The following is a description of a gene set: from publication Onken MD, Ehlers JP, Worley LA, Makita J, Yokota Y, Harbour JW (PMID 16651410) Genes up-regulated in uveal melanoma: class 2 vs class 1 tumors. species: Homo sapiens Human Gene Set: ONKEN_UVEAL_MELANOMA_UP Microarray gene expression profiling is a powerful tool for generating molecular cancer classifications. However, elucidating biological insights from these large data sets has been challenging. Previously, we identified a gene expression-based classification of primary uveal melanomas that accurately predicts metastatic death. Class 1 tumors have a low risk and class 2 tumors a high risk for metastatic death. Here, we used genes that discriminate these tumor classes to identify biological correlates of the aggressive class 2 signature. A search for Gene Ontology categories enriched in our class-discriminating gene list revealed a global down-regulation of neural crest and melanocyte-specific genes and an up-regulation of epithelial genes in class 2 tumors. Correspondingly, class 2 tumors exhibited epithelial features, such as polygonal cell morphology, up-regulation of the epithelial adhesion molecule E-cadherin, colocalization of E-cadherin and beta-catenin to the plasma membrane, and formation of cell-cell adhesions and acinar structures. One of our top class-discriminating genes was the helix-loop-helix inhibitor ID2, which was strongly down-regulated in class 2 tumors. The class 2 phenotype could be recapitulated by eliminating Id2 in cultured class 1 human uveal melanoma cells and in a mouse ocular melanoma model. Id2 seemed to suppress the epithelial-like class 2 phenotype by inhibiting an activator of the E-cadherin promoter. Consequently, Id2 loss triggered up-regulation of E-cadherin, which in turn promoted anchorage-independent cell growth, a likely antecedent to metastasis. These findings reveal new roles for Id2 and E-cadherin in uveal melanoma progression, and they identify potential targets for therapeutic intervention., and this is the list of marker genes: IFITM3, PTRH2, NR4A2, CBFB, GDF15, RCBTB1, CYC1, TYMP, GALNT7, SOS1, PTGS1, FKBP1A, NUDT15, LRP1, SSX1 (NCBI Gene Id 6756), SORD, FNBP4, CTSB, NETO2, TTC3, CDKN1A, USP48, PKD2, ANP32E, IMPA1, MTSS1, PPIP5K2, ZC3H7A, ATP6V1H, LTBR, ATG14, PFN1, TRAF5, NOTCH2NLA, PSME4, MTERF3, TRA2A, CDC42EP3, UBE2V2, THUMPD2, LSM14A, FLNC, UBR5, MPC1, APPBP2, PCMT1, ATM, SLC2A3, STK3, BAZ2B, LGALS3, BICD2, ZNF706, EXOSC8, GPR107, PHF20L1 (PHD finger protein 20 like 1), BTN3A3, TERF1, UFL1, DPY19L4, GSPT1, COX6C, PLEKHF2, MMP2, KPNA2, ZNF623 (zinc finger protein 623), FASN, HERC2, SHTN1, MEX3C, ADGRL1, DENND5A, SPAST, INPP4B, RPL37A, ASS1, TAGLN2 (NCBI Gene Id 8407), SRSF7, NASP, CDC25B (NCBI Gene Id 994), CDC42BPB, PNISR, PSAP, ABTB2, ASB9, PSMB9, SLC23A2, AHI1, HNRNPD, ANK2, PSME2, SLC25A13, PDLIM1, GPAA1, GEMIN6, RPS6KA2 (NCBI Gene Id 6196), CALM1, RAI14, ARRB1, AUH, DLST, CTPS1, MSN, PRKCA, ARMC9, MTDH, FADS3, YTHDF3, STS, PILRB, CUX1, LY96, PITPNC1, H2AX, PRDX4, AHNAK2, POLR2K, HK2, KCND3, CASP1, PARP12, SPTBN1, COPS8, HLA-DMA, RABGAP1L (RAB GTPase activating protein 1 like), POLR3C, PCGF2, SOCS2, GTF3A, ASAP2, HDAC4, FNBP1, C1QB, MED15, WWP1, CTSH, TAF2, ACIN1, GGNBP2, FEZ1, TMEM70, CALR, BAIAP2, POLA1, SRSF11, SCD, CDH1, ELOVL6 (NCBI Gene Id 79071), RDX, P4HA1, TBC1D16, DNAJC10 (DnaJ heat shock protein family (Hsp40) member C10), TYMS, GATAD1, PIK3C2A, PDE4A (phosphodiesterase 4A), EFHC1, DAPK1, GOLM1, RECQL, NRDC, TOR1AIP1, PEA15, PTDSS1, ZMYND8, SLC45A2, MFSD10, ARFGEF2, SNRPA1, ME2, IFITM2, STOM, PTPRM (NCBI Gene Id 5797), CHD3, RAP1GDS1, HSD17B12, TPR, BOP1, HACD1, AZIN1, COL18A1, C8orf44, COL4A1, NSMF, TNPO1, PTPA, OPN3, PCNA, IARS1, MAP3K12, ELOC, SORL1, ABCC1, HTATIP2, VOPP1, GUSB (glucuronidase beta), KPNB1, WSB1, MPHOSPH9, G6PC3, JAG2, EIF4G3, LAPTM5 (NCBI Gene Id 7805), MGAT2, SPATA20, CCND2, PTGER4, GSDMD, GLRX2, UGGT2, MET, SEC63, NDUFA6, TGS1, MINK1, SH3YL1, PTPRC, SNW1, SPARC, NFATC2IP, MICAL1, CAVIN3, GNS, ZC3H11A, UBXN2B, ADGRA3, DAP, PPP1R12A, FZD7, HLA-B, GDI1, ASAP1, CTSS, PFKP, RALGAPA1, DMXL1, CDK1, HLA-E, OXCT1, RUFY3, TSPYL5, SCO2, SACS, ADAM23, DLG5, GREB1, TNKS2, NIPA2, FGF13, ANXA4, TM9SF2 (transmembrane 9 superfamily member 2), HCLS1, CDC42BPA, CBR1, BIN1, SHC1 (NCBI Gene Id 6464), LZTS1, PHF11, RBFOX2, NACC2, RRN3, CCNDBP1, BTAF1, BMERB1, BAG2, SOD2, SNRNP35, PHF21A, MYO18A, OTUB1 (NCBI Gene Id 55611), C2, ATMIN, CDK5R1, HMGXB3, MXRA7, PLAAT4, TENT4A, PSMA7, TSPAN31, RBM28, LETM1, OLFM1, SNRPG, GNPTAB, ENY2, RAP1GAP, PSRC1, NFIL3, ATP2A2, ZNF84, CHD7, LYN, FABP3, ABR, CYP51A1, DLGAP5, SERINC5, TMEM164, ACADVL, RPL17, LAMC1, NDRG1, PRKDC, ACSL1, RNF139, FHL1 (NCBI Gene Id 2273), IGFBP7, WBP1L, DDX60, SULT1A2 (NCBI Gene Id 6799), FZD5, ADI1, WLS (Wnt ligand secretion mediator), ZBTB10, PSMB1 (proteasome 20S subunit beta 1), CHST3, MARCHF7, SNX16, PDS5A, YWHAZ, TCF12, RBMS1, SYNCRIP, ANXA11, CYRIB, INTS8, TM2D1, AK4, PKM, MEIS2, MAP4K3, CKS2, RAB31, EXT1, ADGRG1, DNAJC13, OXR1, CDK17, NSMAF, ALK, VLDLR, CPNE3, RAD21, HAUS3, SPTAN1 (spectrin alpha, non-erythrocytic 1), KIF14, C1R, EGR3, TPD52, ACLY, PSMA3, KIAA0232, MACF1, SHFL, AP1G2, RPGR, APP, SLC1A4, WARS1, RMDN1, ACACB, TMEM87A, IFITM1, WWTR1, MAD1L1, LARP1, HSPH1, ORMDL2, IER5, DDX39A, TMCO1, UBXN4, PAM, ATP2B1, NCOA2, TSC22D1, NPAS2 (NCBI Gene Id 84195), NF1, ASTN2, CHCHD7, VSIG10, FXYD6, PTPN2, HMGB2, RDH11, PTK2, RIN3, LAPTM4B, MSL1 (MSL complex subunit 1), CNIH4, MRPL19, EBAG9, GSS, CAMSAP2, CPSF1, PLTP, ZNF267, CEBPD, SLC22A18, CDC27, NDUFB8, REV3L, MLH3, NTAN1, LHFPL2, CDC16, GPR143, RCAN1, RHOT1, RAB2A, MRPL15, EMP1 (epithelial membrane protein 1), CIAO1, C1QA, VCPKMT, SLC25A32, NUCB2, MRPS28, ISG15, MORC2, MRM2, WASHC5, NPIPB3, C8orf33, PCDH7, FASTKD1, CLIP1, PLOD3, SMARCA5, MAP2K3, DERL1 (derlin 1), TMEM168, ENOSF1 (NCBI Gene Id 55556), IQGAP1, ZNF451, SUPT16H, NQO1, CCNA2, TCEA1 (NCBI Gene Id 7865), UBE3A, ZFP36L2, WIPI1, MED7, DIAPH2, NUMB, HCFC1R1, TRIO, GPR89B, B2M, AUP1, LHFPL6, MT2A, NUSAP1, ATP6V1C1, ARFGEF1, IDE, SPARCL1, REEP1, PFKFB3, EIF4EBP3, SAFB2, TPP2, RHOB, HERC2P9, PIN4, ADGRE5 (NCBI Gene Id 976), S100A13, PXDN (peroxidasin), PEX2, CXCR4, SLC20A1, CSPG4, CERS2, NANS, FBXL7, COQ2, COTL1, ANKRD46, LYPLA1, SMARCA4, VPS13B, CDK19, PUM3, SLC38A6, CAPN2, HNRNPDL, ADCY3, LRRFIP1, CD58, COL1A2, WWC3, P4HA2, BCOR, IER3, RAD54B, SGK1, IFI16, HLA-G, DOCK9, KNOP1, HTRA1, BDH2, DOCK4, SLC7A8, TRIM22, ADCY1, NT5E, LAMA5, ITGA6, NT5DC3, COPS5, ZDHHC11, POMP, C2CD2, TRBC1, MAN1C1, CTSK, TTC28, ETS2, DUSP14, TMEM165, KDR, DCAF8, TPBG, FAM174B, ANKRD10, FADS1, VMP1, FRY, AP1S1, UBE2S, APOD, EMC2, TIMP2, PFN2, PTP4A3, UBE2K, LGALS8, CERS6, FAM193A, FAM216A, EML3, BAZ1A, ADAMDEC1, PCGF3, TNFAIP2, SGSH, IRAK1, GNAS, SYNE2, JMJD1C, SEC24D, GBA1, BASP1, CD55, ADAM17, CNOT4, RNF144A, COL6A1, PGAM1, CLIC4, EGR1, ACTB, HDAC1, CENPU, TBC1D1, DECR1, TYROBP, SLC35E3, FGF9 (fibroblast growth factor 9), ATP10A, IGF2R, NUP88, MRPL40, NCOR1, NME4, CD74, RGS20, VPS28, SMAD3, KDELR3, PDE10A, SETDB1, RBM25, MACROD1, IFNGR1, LAMTOR2, ACKR3, PTPRA, TRAM1, LINC00342, LDB3, OGT, MR1, ABHD3, QDPR, EFR3A, PRUNE1, TBL2, NAT10, SOX13, RETREG1, HNRNPA1, TMEM38B, ITPR2, LDLRAD4, S100A1, TRPV2, HLA-DRA, FCER1G, CLEC2B, HLA-J, PSPC1, CCDC93 (coiled-coil domain containing 93), CELSR1, SCAMP4, TPST2 (tyrosylprotein sulfotransferase 2), MGST2, PIGA, ACTR3, PLXNC1, HLA-DRB1, STAM, S100A6, MARK3, GCH1, IDH2, SEPTIN10, LAP3, C4A, MYO6, PIK3C3, PRP4K, RB1CC1, SEPTIN2, SQLE, TFPI2, SDHA, FXYD5, NBN, ALG5, MCM4, EMC7, RIDA, CTSC, SOAT1, CREM, FABP5, LY6E, ADCY9 (adenylate cyclase 9), CTTN, DGAT1, TRRAP, PLPP3, NPIPB15, LGALS1, ME1, TRIB1, COMT, PGAP1, CAPRIN2, FAR2, BAZ1B, ASF1A, NPIPA1, URB1, TIA1, CDK2AP1, SGCB, TMEM214, FKBP11, PTOV1, LRP8, NUP58, SFPQ, DNAJC2, NOX5, TRIM33, IPO9, SEL1L3, MEMO1, ARMC1, PMM2, ZNF410 (NCBI Gene Id 57862), IFFO1, UBE2W, TCERG1, GFUS, GOLPH3, S100A11, GRINA, PRRC2C, RGS5, MAN2A2, TDG, MTR, SP110, CLINT1, MCM3AP, AACS, SMCHD1, KCTD12, SLC11A2 (solute carrier family 11 member 2), STAT1, CITED1, PCDHGC3, MYOF, AKAP9, EMP3, CASP8AP2, ATP9A, LUC7L3, TAPBP, SLC1A1 (NCBI Gene Id 6505), ALG13, CELF2, HLA-DPB1 (major histocompatibility complex, class II, DP beta 1), ZNF7, SREK1, ARPC2, NXN, ZEB2, SAMD4A, SLC35A1, EXOSC4, AKAP13, TACC2, ZHX3, HSPB8, LUC7L2, TRAPPC10, TRAF3, PDXK (pyridoxal kinase), ARHGAP1, SULT1A1, SH3BGRL3, AGO2, CCN3, KDM7A, PUS7, SFI1, PHACTR1, PPP1R10, STAT6, TBK1, HLA-DPA1, PDE4DIP, EIF4E2, SFXN3 (NCBI Gene Id 94083), BOLA2, CADM1, TNFAIP8, MTCL1, TRAPPC13, IRF9, NENF, KIT, SPIDR, SULT1A3, MBD2 (NCBI Gene Id 8932), ACTN4, NEK3, MTFR1, SAP30, SYNPO, MRPL13, FRMD4B, HLA-F, GEM, BIRC7, PHLDA2, SLC39A4, RAPGEF4, SPON2, SAR1B, MTX1, LACTB2, UQCRB, ASPH, PSMD14, WIPF1, ODR4, CSPP1, AGAP1, DGCR2, AMZ2, APOBEC3G, GLA, NOTCH3, GPM6B